The following is a description of a gene set: IFN-gamma transcriptional responses in control and IFN-gamma primed primary human macrophages Genes up-regulated in macrophages stimulated by IFNG for 24h: control versus primed by IFNG. Human Gene Set: GSE1925_CTRL_VS_IFNG_PRIMED_MACROPHAGE_24H_IFNG_STIM_UP species: Homo sapiens from publication Hu X, Park-Min KH, Ho HH, Ivashkiv LB (PMID 16148108), and this is the list of marker genes: ARID3A, CHL1, STK36, RNASE3, GIMAP4, IFIT1B, HNRNPA1, SYNE4, PIGK (phosphatidylinositol glycan anchor biosynthesis class K), NR4A1, CCDC71L, UBFD1, PSMB9, PTPN13, COL11A2 (NCBI Gene Id 494120), HOXD3, MYH3, PTGIR (prostaglandin I2 receptor), YKT6, LAT2, MBNL1, RBM26, ADPRM, REL, GSTO1, CHD7, RNF7, SNHG6, AP4S1, PKP2, ETFBKMT, TMCO1, ITM2A, SDHAF1, MYH2 (NCBI Gene Id 4620), ASH1L, ARG1, IFIH1, PDCD1, SHISA5, LYSMD2, DTD1, NME4, FMOD, SRGN, GPR83, PRPF38B, FGF9, ACRV1, INSM1, MRPS14, EIF2AK4, SMAD4, HLA-G, PPFIBP2, MS4A6A, ATP5MG, KIF3A, CNTN3, NDUFAB1, HPCA, CRYBG1, RPS7, NDUFC1, ZFP42, LGALS3BP, TENT5C (NCBI Gene Id 54855), HNRNPK, PTPN2, IL12RB1, IL9R, NFIB, PCNT, RPS27L, PFKP, PROS1, EEF2K, NLN, SH3BGRL2, HIVEP2, COL3A1, GBP4, DDX51, MRM3, RTL8B, UNG, MX2, IRF4, STAT1, WDR55, RAB11FIP5, AMBP, GJD2, PSME2, GP5, CNN2, EOMES, MKRN1, SNRPD1, NMI, RAB5C, IRF1, ZNF436 (NCBI Gene Id 80818), MED14, MRE11, ABCC2, PSMC4, ABCB1, CXCR5, RELB, GZMA, LARP4B, PLGRKT, PDC, SNX5, GNB5, SLC5A1, S100A16, NDST2, SSR4, METTL5, ETNK1, IRGM, IRS1, INSRR, HOXB3, CD320, GRIA3, PRTN3, ITIH5, UNC93B1, PER1, MIDN, JARID2, FURIN, SLC25A4, GBP2, EGR2, PPP3CA, NT5C3B, ZSCAN26, PNO1, PPRC1, SUPT4H1, ZDHHC6, ALAS2, SPA17, SH3BP2, SQSTM1, GADD45B, LETM1, DIDO1, RASD1 (ras related dexamethasone induced 1), TNFRSF8, DNAJC1, ICAM1, ELF5, COX6B2, IKZF1 (IKAROS family zinc finger 1), WNT5A, B2M (NCBI Gene Id 567), ZNF532, NAB2, EPHX1, CD40, COX17, BCL2L11, PKIB, METTL3, CACYBP, NFKB2, PDGFRA, FABP3, NFE2L2, PDCD6, METTL1, USP18, CFAP68, TRAPPC14, SFTPD, SELENOK, LNX1, ANKIB1, TAF1D, CYP3A4, NME1, BPHL, HRG, IFI27, C1QTNF12, TRAF3, CNN3, PCK1, MNT, PJA1, SLC25A47, EPS8, EBNA1BP2, TXNL4A, COMTD1